Given this list of marker genes Pdcd5-ps, Sh3glb1, Hspa1l (heat shock protein 1-like), Prkaa1, Gsk3a, Adcy10, Pmaip1, Fbxw7, Tomm70a, Pdcd5, Bbc3, Ptpn5, Tomm7, here is a description of the gene set: studied in species Mus musculus Any process that activates or increases the frequency, rate or extent of establishment of protein localization to mitochondrion. Mouse Gene Set: GOBP_POSITIVE_REGULATION_OF_ESTABLISHMENT_OF_PROTEIN_LOCALIZATION_TO_MITOCHONDRION